The following is a description of a gene set: from publication Chen Y, Wang X (PMID 31504780) studied in species Mus musculus Mouse Gene Set: LET_7D_5P Genes predicted to be targets of miRBase v22 microRNA mmu_let_7d_5p in miRDB v6.0 with MirTarget v4 prediction scores > 80 (high confidence targets)., and this is the list of marker genes: Diaph2 (diaphanous related formin 2), Yod1, Fgf11, Fasl, Lgr4, Stx3, Map3k2, Prpf38b, Myo1f, Trim6, Nol4l, Plekhg6 (NCBI Gene Id 213522), Masp1 (NCBI Gene Id 17174), Ddi2, Ltn1, Clasp2, Leprotl1, Cntrl, Cnot6l, Mycn, Thoc2, Slc2a12, Hip1, Adamts15, Col5a2, Gabra6, Dusp1, Alox8, Psd3, Gdf6 (growth differentiation factor 6), Cep135, Smug1, Rbms2, Dnajc1 (DnaJ heat shock protein family (Hsp40) member C1), Lin28b, Hdlbp, Zfp282, Cbx2, Dmd, Liph, Igf2bp2, Cercam, Col3a1, Intu, Trhde, Pik3ip1, Zswim5, Limk2, Il6, Lbr, Syt11, Kdm3a, Bzw1, Fgd6, Styk1, Tmc7, Ahctf1, Trabd, Eea1, Lrig2, Slc25a24, Begain, Sigmar1, Trim67, Tnfaip8l3, Igdcc3, Alg11, Trim41, Slc25a27, Utrn, Rbfox2, Adrb2, Has2, Plxnd1, Col4a2, Slc66a1, Arid3c, Hook1, Cpeb1, Ppargc1b (NCBI Gene Id 170826), Pappa, Slc20a1, Klf8, Kctd17, Zfp512b, Stk40 (serine/threonine kinase 40), Cemip2, Thrsp, Snx30, Pxdn, Zbtb5, Dtx4, Pcgf3, Efhd2, Bsn, Igf2bp3, Ap1s1, 5031439G07Rik, Tmprss2, Col1a2, Smim3, Ints6l, Tmod2, Plxnc1, Fam174a (family with sequence similarity 174, member A), Ddx19b, Greb1l, E2f5, Stxbp5 (NCBI Gene Id 78808), E2f6, Nphp3 (nephronophthisis 3 (adolescent)), Skil, Agap1, Pogz, Fign, Rfx6, Rgs16, Zfp583, Pald1, E2f2, Cep120, Plekho1, Hand1, Ppp2r2a, Rgs6 (regulator of G-protein signaling 6), Ttll4, Usp24, Nipal4, Klk10, Acat1, Fbxl12, Arhgef15, Rab8b, Fndc3a, Tmprss11f, Stx17, Galnt2, Katnbl1, Stard13, Usp38, Tgds, Slc16a14, Faxc, Igf1r, Onecut3, Fignl2, Prr23a3, Sall4, Arid3b, Tet3, Ndst2, Zbtb39, Col4a1, Eef2k, Mdfi, Pard6b, Mdm4, Bcat1, Igf2bp1, Mapk8, Zmat4, Elp1, Nemp1, Kif2b, Fnip2, Wnt9a, Pla2g3, Ccnj, Tgfbr3 (transforming growth factor, beta receptor III), Thoc1, Cpa4, 9930012K11Rik, Slc22a23, Nme6, G6pc2, Pitpnm3, Limd2, Soat2, Gnptab, Cgnl1, Lipt2, Wdfy3, Gatm, Abcb9, Gramd2b, Pbx1, Gpatch2, Vstm5 (V-set and transmembrane domain containing 5), Hif1an, Lrig3, Map3k1, Nr6a1, Rab11fip4, Rspo2, D630045J12Rik, Plekha8, Prtg, Smarcad1, Slc38a9, Fras1, Tbkbp1, Sowaha, Myorg, Cpeb2, Rictor, Entrep2, Nap1l1, Slf2, Cdc34, Hmga2, Crb2, Adamts12, Lin28a, Pbx3, Il13, Tspan5, Nras, Edn1, Pcdh19, Slc10a7, Klhl6, Mapk6, Lpgat1 (NCBI Gene Id 98667), Dnaja2, Plpp6, 2310022A10Rik (RIKEN cDNA 2310022A10 gene), Zfp275, Map4k3, Cbx5, Etnk2, Ccr7, Cflar, Cry2, Plpp5, Ercc6 (NCBI Gene Id 319955), Trim71, Ptafr, Adamts8, Ccnd2, Ddx19a, Zfyve26, Gga3 (NCBI Gene Id 260302), Atp2a2, Dusp22, Kctd21, Rdx, Wnt9b, Dcaf15, Bach1, Rbpj, Arhgap12, Gng5, Zc3hav1l, Hectd2, Snn, Gas7 (NCBI Gene Id 320013), Taf9b, Acvr1c, Onecut2, Mxd1, Arid3a, Gpatch3, Tmem65, Gpcpd1, Adrb3, 1700017B05Rik, Stimate, Hic2, Cldn12, Cd200r1, Fam135a, Dtx2, Osmr, Zfp975, Ybey (ybeY metallopeptidase), Apbb3, Sec16b, Senp2, Ppp1r16b, Col27a1 (NCBI Gene Id 66652), Rufy3, Coil, Tgfbr1, Tmem198b, Galnt1, Txlng, Tyk2, Xkr8, Dlc1, Igdcc4, Gxylt1, Fnip1